The following is a description of a gene set: Genes predicted to be targets of miRBase v22 microRNA hsa-miR-4684-3p in miRDB v6.0 with MirTarget v4 prediction scores > 80 (high confidence targets). species: Homo sapiens from publication Chen Y, Wang X (PMID 31504780) Human Gene Set: MIR4684_3P, and this is the list of marker genes: RGS21 (regulator of G protein signaling 21), FN3KRP, IHO1, UBE3A, UCHL3, FAM110C, GPR83, TMEM45B, AZIN1, GSKIP, SLC25A40, UBN1, ZEB2, ATG12, ZNF546, DCAF13, NEUROD6, RBM39, SP4 (NCBI Gene Id 6671), GIGYF2, HDAC9, AADACL2, ZNF37A, SDR42E1, HTR2C, NADK, TSC22D2, RPS6KB1, SLC17A6, HFM1, KCNK10, IMMT, C1orf21, MME, MAP2 (NCBI Gene Id 4133), MEF2C, SYT1, FCER1A, ZAR1L, PPP1R15B, PLXNC1, GALNT6, CDCA8, KIAA0586, SOCS5, SALL1, PRDM8, MTAP (NCBI Gene Id 8008), SART3, SETD7, YAE1, MAP3K21, C14orf28 (chromosome 14 open reading frame 28), AGTR1, YAF2, GATA6, NUFIP2, CEP128, GRHL3, DENND5A, QKI, MMP19, DENND1B, HNRNPD, POLK, RBMXL1, TNRC6B, INHBA, AKIRIN1, ZNF689, ANKRD11, SPRY2, BTC, TUBB, STK26, SMG7, RIMS2, CLEC3A (NCBI Gene Id 10143), GSTA5 (NCBI Gene Id 221357), NPHP3, ITPK1, ZAR1 (zygote arrest 1), CHIC2, PKIA, UNG, ST18, FOXC1, MACROH2A1, SRSF10, BNIP2, NWD2, RASSF5, GPR12, SEL1L (NCBI Gene Id 6400), UFD1, PAIP2B, KDM5A, NTRK2, ELOVL4, TMED2, DMXL1, SLC4A8, TPSG1, PREP, BMPR2, CAMK2N1, SNX13, DCTN3, PRKAA2, PCDH9, TNFRSF21, KRTAP1-5, LAMC2, MID1, PTHLH (parathyroid hormone like hormone), ABCA1, CABLES2, CHRNA6, UBN2, OLFML2A, NAALADL2, CACNA1B